The following is a description of a gene set: Human Gene Set: GOMF_G_PROTEIN_BETA_SUBUNIT_BINDING studied in species Homo sapiens Binding to a G-protein beta subunit., and this is the list of marker genes: GNG3, GNG13, GNG4, F2R, RGS11, RASD1, RGS7, GNG12, GNG14 (NCBI Gene Id 648044), GNG5, CCT5, GNG2, RASD2, GNG11, GNG10, GNGT2, GNGT1, GNG8, GNG5B, F2RL1, OPRM1, GNG7, GRIA1